Given this list of marker genes ASIC1, GRIK1, TPCN2, ASIC3, SHROOM2, GRIN1, GRIK4, ASIC4, TPCN1, SCNN1G (sodium channel epithelial 1 subunit gamma), GRIK3, ASIC2, SCNN1D, GRIK2, SCNN1A, GRIK5, SCNN1B, ASIC5, here is a description of the gene set: Human Gene Set: GOMF_LIGAND_GATED_SODIUM_CHANNEL_ACTIVITY Enables the transmembrane transfer of a sodium ion by a channel that opens when a specific ligand has been bound by the channel complex or one of its constituent parts. species: Homo sapiens